Given this list of marker genes EXOSC10, PPIAL4A, TCAF1, TOX3, DUSP11, PSMG2, FAF2, here is a description of the gene set: Human Gene Set: QI_PBMC_ZOSTAVAX_AGE_50_75YO_1DY_UP Genes up-regulated in peripheral blood mononuclear cell 1d vs 0d in seniors (50-75) after exposure to Zostavax, time point 1D. Comment: S2 Table has Illumina probe IDs species: Homo sapiens from publication Qi Q, Cavanagh MM, Le Saux S, Wagar LE, Mackey S, Hu J, Maecker H, Swan GE, Davis MM, Dekker CL, Tian L, Weyand CM, Goronzy JJ (PMID 27764254) Vaccination with attenuated live varicella zoster virus (VZV) can prevent zoster reactivation, but protection is incomplete especially in an older population. To decipher the molecular mechanisms underlying variable vaccine responses, T- and B-cell responses to VZV vaccination were examined in individuals of different ages including identical twin pairs. Contrary to the induction of VZV-specific antibodies, antigen-specific T cell responses were significantly influenced by inherited factors. Diminished generation of long-lived memory T cells in older individuals was mainly caused by increased T cell loss after the peak response while the expansion of antigen-specific T cells was not affected by age. Gene expression in activated CD4 T cells at the time of the peak response identified gene modules related to cell cycle regulation and DNA repair that correlated with the contraction phase of the T cell response and consequently the generation of long-lived memory cells. These data identify cell cycle regulatory mechanisms as targets to reduce T cell attrition in a vaccine response and to improve the generation of antigen-specific T cell memory, in particular in an older population.